Given this list of marker genes MIR17, MIR105-1, NFKBIB, TRAF6, CCDC47, CCL2, HAVCR2, TNF, IL36B, PDCD1LG2, MIR224, CD180, KMO, BCR, BTK, TNIP3, CD200 (CD200 molecule), PYCARD, DEFB114, TSPO, CXCL6, OPRK1, TNFSF4, MIR19B1, TREM2, PRKCE, DEFB131A, PRDX2, CXCL13, CDK4, TNFAIP3, DEFA4, SASH1, CLEC7A, IRF3, FBH1, LILRB2, EPHB2, SHPK, CAPN2, FZD5, MIR766, SERPINE1, TLR6, CD6, CDC73, MIF, PLAA, SPON2, PLCG2, NOS2, LACRT, ARID5A, CMPK2, TLR2, SBNO2, FCGR2B, IL36G (NCBI Gene Id 56300), NR1H3, NR1H4, GBP2, PPBP, TLR10, FCAR, TLR1, JAK2, MIR433 (microRNA 433), CAMP, MIR223, DAB2IP, RELA, HMGB2, IL1B, PF4, MIR20A, LY86 (lymphocyte antigen 86), CCL27, LY96, CX3CL1, BMP6, MEF2C, CARD17P, LYN, IL36A, TXNIP, KLRC4-KLRK1, LCN2, MYD88, TRIM41, EFNB2, MIR187, CSF2 (NCBI Gene Id 1437), CD40, HSF1, WFS1, PPP1R15B, CXCL5, ATG10, HCK, CXCL10, PPM1E, NFKBIA, PLSCR3 (NCBI Gene Id 57048), HDAC5, GSTP1, CD55, MIR342, MRC1, PTPN6, IGFBPL1, MAP2K3, PTPN11, PTAFR, TNFRSF1B, PPARD, TBXA2R, ABCA1, SPI1, DEFA5, CASP7, HMGCS2, RBM14 (NCBI Gene Id 96086), NLRP7, EDNRB, TLR4, KLRK1, NFKBIZ, LBP (NCBI Gene Id 3929, lipopolysaccharide binding protein), PLSCR4, DEFA6, SIRPA, CACTIN, MTDH, VIM, DEFA3, IRGM, PDCD4, DEFA1, TICAM1, ZFP36, CX3CR1, IRAK3, RARA, TIRAP, CCR5, MAPK1, LDOC1, IRAK2, UPF1, MAPK3 (mitogen-activated protein kinase 3), ABL1, TNIP1, SCIMP, NOTCH2, MAPK14, SIGIRR, IL6, GBP5, MAPK8, MIR21, ZC3H12A, CXCL8, XBP1, HSPA5, MIR140, IL24, WNT5A, NFKBIL1, PRKCA, GBP3, STAP1, MUS81, ADAMTS13, RIPK2, LTF, TLR5, CD68, MIR6869, IL10, GFI1, DDIT3, NFKB1, SMC1A, BPI, BCL10, SELENOS, CDK19, TLR9, IL37, ANKRD1, IRAK4, LILRA2, B2M, HMGB1, PTPN22, PF4V1, NR1D1, TRIB1, SCARB1, MMP9, PDE4B, IL36RN, IRAK1 (NCBI Gene Id 3654), MALT1, CTSG, AXL (AXL receptor tyrosine kinase), PAF1, IL12B, NUGGC, SYK, CD274, CARD16, CCL28, CDA, CD86, CSF3, CEBPE, AICDA, ADAM9, CARD8, MMP8, CD80, NR1I2, DEFB118 (defensin beta 118), AKT1 (NCBI Gene Id 207), LILRB1, GIT1 (NCBI Gene Id 28964), RHOA, MIR146A, TIFAB, PRPF8, MIR19A, IL1F10, CHMP5, IL18, AHR, HADHB, TIGAR, ZMPSTE24, CYRIB, MIR128-1, SLX4, CEBPB, EIF2AK3, NOTCH1, ABCB1, ASS1, PABPN1, TRIM5, LITAF (NCBI Gene Id 9516), MMP3, GSK3B, TNIP2, GATA1, SLC7A5, DEFB124, IL1A, CTR9, IRF8, APAF1, TP53, AKAP8, TICAM2, MAP2K7, DEFA1B, EME1, NLRP3, GHSR, ACOD1, NOS3, TMCO1, IRF5, CASP1, CD36, CD14, CXCL9, NOD2, here is a description of the gene set: species: Homo sapiens Any process that results in a change in state or activity of a cell (in terms of movement, secretion, enzyme production, gene expression, etc.) as a result of a biotic stimulus, a stimulus caused or produced by a living organism. Human Gene Set: GOBP_CELLULAR_RESPONSE_TO_BIOTIC_STIMULUS